Given this list of marker genes Sigirr, Plscr1, Cd163, Saa3, Cnr1, Il1rn, Ccr5, Il1b, Hp, Mrgpra3, Saa1, Ins1, Serpina3n, Hfe, F2, Reg3g, Serpina1a, A2m, Stat3, Orm1, Ptger3, Ccl5, Tnfrsf11a, F8 (coagulation factor VIII), Il6, Tnf, Orm2, Trpv1, Ugt1a1, Ahsg, Stat5b, Ptgs2, Lbp, Il1a, Saa2, Reg3a, Epo, Serpina1b, Ednrb, Tnfsf11, Crp, Reg3b, Ptges, Ass1, Fn1, Tfr2, Ins2, Tfrc, Serpinf2, Orm3, Itih4, here is a description of the gene set: Mouse Gene Set: GOBP_ACUTE_PHASE_RESPONSE species: Mus musculus An acute inflammatory response that involves non-antibody proteins whose concentrations in the plasma increase in response to infection or injury of homeothermic animals.